Given this list of marker genes Ntf5, Rac1, Grb2, Fyn, Ntrk2, Frs2, Sos1, Bdnf, Plcg1, here is a description of the gene set: studied in species Mus musculus Signaling by NTRK2 (TRKB) Mouse Gene Set: REACTOME_SIGNALING_BY_NTRK2_TRKB